Given this list of marker genes TMEM260, SETBP1, OTUD6B, EXT2, USP9X, SOX5, SLC6A9, CCDC22, GLI3, DHCR7, PPP1R21, ASXL1, TBCK, GJA8, TMEM94, MAPK1, TRAF7, MED12, SMAD4, UBE2A, INTS1, KAT8, MYH3, PUF60, BLTP1, CPLX1, SOD1, WIPI2, RTL1, RAB3GAP1, ARX, BPTF, GJA5, MYOD1, MED25, ATN1, HNRNPK, SNRPN, XYLT2, MEG3, CHST11, PDZD8, CREBBP, RAB3GAP2, SF3B4, RSPRY1, TELO2, ZFX, ZNF407, GDF6, TMCO1, RAB11B, SIN3A, DLK1, ACTB, TPM2, NEK9, PCGF2, EBP, CTU2, DDX6, SLC35C1, TCF4, CDC42, EP300, ATP6V1E1, HUWE1, ERI1, INTS8, THOC6, GNPNAT1, FGFR2, CCDC47 (NCBI Gene Id 57003), EZH2, PIEZO2, here is a description of the gene set: Overlapping toe species: Homo sapiens Describes a foot digit resting on the dorsal surface of an adjacent digit when the foot is at rest. Initially clawing may be dynamic and only noticeable on walking. Over time the plantar plate tears, subluxation occurs at the metatarsophalangeal joint (MTPJ), and the deformity becomes permanent. Human Gene Set: HP_OVERLAPPING_TOE